Given this list of marker genes NHERF1, MSH2, HASPIN, TOM1L2, HEXIM2 (NCBI Gene Id 124790), MIR30C2, MAP3K20, PTEN, CCNB1, MIR15A, CDKN1B, TFDP3, VPS4A, BUB1B, ACVR1, CTDSP1, IL10, MIR193A, CDCA8, TRIM35, SYF2, GPR132, BRCA1, CDKN2D, MAD1L1, RAD50, MAD2L1, PINX1, PKMYT1, PLK1, MUS81, ANAPC15, TIPIN (NCBI Gene Id 54962), MIR638, INTS3, ZFP36L1, MIR19B1, KLHL22, APC, NAE1, AVEN, INIP, BRINP2, CDK1, BUB1, DGKZ, CDKN2B (cyclin dependent kinase inhibitor 2B), ETAA1, RAD9B, PLK3, KLF4 (NCBI Gene Id 9314), EME1, BTN2A2, TRIP13, PKD2, BARD1, MYO16, XPC, FAM107A, CACNB4, FOXC1, MIR29C, ZNF207, NOP53, SETMAR (NCBI Gene Id 6419), MIR137, MIR26A1, FBXO7, PML, RBL1, XRCC3, ZFP36L2, BRCC3, CDK5RAP2, LCMT1, INHBA, DCUN1D3 (defective in cullin neddylation 1 domain containing 3), RGCC, MIR362, PABIR1, RFPL1, GAS1, TP53 (NCBI Gene Id 7157), CDK2AP2, FBXO31, MIR29A, ATM, IK, FHL1, CHFR, BUB3, FANCD2, PRAP1, CHEK1, IER3, TPRA1, MIR133B, MDC1, ABL1, RPS27L, WEE1, UIMC1, MUC1, CDKN1C, CHMP4C, KNL1, CRLF3, KNTC1, NBN, NABP2, STK35, SKA3, ZNF830, MIIP, BABAM2, E2F7, EZH2, BCL2, TEX14, TRIAP1, CLSPN, CDC6, MBTPS2, RBBP8, FOXN3, CDKN1A, RFWD3, BRINP1, BMP7, GIGYF2, PRMT2, CTDSP2, TOM1L1, DONSON, CTDSPL, PTPN3, FZD3 (frizzled class receptor 3), TAOK3, NME6, MIR451A, ZC3H12D, PRKDC, RAD21, INCENP, TAOK2, SCRIB, SKA1, BRSK1 (NCBI Gene Id 84446), CDK5RAP3, TNF, RPA2, HUS1B (NCBI Gene Id 135458), PSMG2, MAD2L1BP, STK33, DACT1, ANGEL2, CDC73, PRP4K, MRNIP, ZFYVE19, MRE11, ABRAXAS1, CTNNB1, GPNMB, MBTPS1, TOPBP1, MIR21, MIR16-1, TTK, GFI1B, SDE2, RBL2, BTG3, KANK2, RBM46, MIR29B1, HUS1, GTPBP4, TRIM39, CCL2, NABP1 (nucleic acid binding protein 1), AURKAIP1, BRINP3, RAD17, MTBP, RINT1, BRD7, FBXO5, ATR, MEIOC, ATF2, PPP1R10, CENPF, CDK2, BLM, MIR134, OVOL1, DUSP1, BABAM1, RB1, FOXO4, NUF2, ZWINT (NCBI Gene Id 11130), TREX1, CHEK2, SPDL1, CDC20, SLFN11, CCND1, ZNF655, BIRC5, FZR1, SPC24, ZW10, TAOK1, RAD9A, BCL6, WAC, PDIK1L, BMP4, GEN1, AURKB, NEK11, ZWILCH, MAD2L2, DLG1, CDC14B, MIR15B, TPR, DYNC1LI1 (dynein cytoplasmic 1 light intermediate chain 1), ORC1, EME2, HECA, DTL, TICRR, NDC80, JADE1, MIR892B, USP44, MIR133A1, MIR195, SPC25, YTHDC2, NLE1, here is a description of the gene set: species: Homo sapiens Human Gene Set: GOBP_NEGATIVE_REGULATION_OF_MITOTIC_CELL_CYCLE Any process that stops, prevents or reduces the rate or extent of progression through the mitotic cell cycle.